The following is a description of a gene set: species: Homo sapiens Human Gene Set: GSE19941_UNSTIM_VS_LPS_AND_IL10_STIM_IL10_KO_MACROPHAGE_UP Bone marrow-derived macrophages were produced from mice lacking IL-10 alone (IL10-def) or mice lacking both IL-10 and the p50/p105 subunit of NF-kB (p50/IL10), and left unstimulated, stimulated with LPS (1 ng/ml) or stimulated with LPS and IL-10 (0.3 ng/ml). Genes up-regulated in IL10 knockout macrophages: unstimulated versus stimulated by IL10 and LPS. from publication Yang HT, Wang Y, Zhao X, Demissie E, Papoutsopoulou S, Mambole A, O'Garra A, Tomczak MF, Erdman SE, Fox JG, Ley SC, Horwitz BH (PMID 21217011), and this is the list of marker genes: SGCE, JUNB, IDO2, FOSL2, TBC1D12, SPATS2, KLF6, FGF3, ANAPC16, GIPR, LY9, SMAP2, PDGFRB, CNTN3, SATB1, TOR1A, JUN, MYO10, ABO, TRIM54, BICDL1, VAX1, PANX1, MPPED2, TSPAN4, DYRK3, KLRK1, SSH2, HOXA11-AS, TNFRSF25, NF2, NAV3, CCDC40, GPR132, ZC3H12D, UFM1, ASB4, KCNIP4 (NCBI Gene Id 80333), PLEKHF1 (NCBI Gene Id 79156), CNGA1, IL18RAP, DCN, SLCO2A1, SH3PXD2B, SIRT6, CDKL2, SNAPC1, CACNB3, SHISA2, NPR1, ALOX12 (arachidonate 12-lipoxygenase, 12S type), YPEL5, GSTA5, DNAJB4, DOK1, VWA8, PAMR1, TNFRSF1A, KRTAP3-3, CHID1, UBA1, SPIC, GLIS3, WDFY4, LETM2, GABARAPL1, COL11A2, PPFIA4, DRD1, DZANK1, SNX20, STX7, NCOA1 (NCBI Gene Id 8648), PLCG2, FAM220A, GEM, SMTNL1, MAP3K6, MOB3A, MN1, MDFIC, MPST, TAX1BP1, CYP11B2, CAVIN2, OSBPL10, ACSBG2, PCED1B (NCBI Gene Id 91523), MCTP2, ZC3HAV1, BICD2, NGF, NECAP2, SMAD3, GPR137, TMEM104, RAD52, LTB4R, B3GNT8, DNAJC16, TMPRSS5 (NCBI Gene Id 80975), SLC39A2, SLIT2, PTPN14, NAPB (NSF attachment protein beta), TLL1, ZFP90, SCAMP3, SELP, SAA1, SP110, ZSWIM9, ALDH1L1, GALNT2, CBY2, FAAP20, FRMD4B, ZNF768, SLAMF1 (signaling lymphocytic activation molecule family member 1), KCNC1, RRM2B, TBXT (NCBI Gene Id 6862), B4GALNT4, LONRF1, STMN4, SKAP2, RDH14, ZNF394, CHMP1B, ZC3H12A, ETNK1, FN3K, MYL9, UPP1 (uridine phosphorylase 1), FERMT3, GREM1, SLC18A1 (NCBI Gene Id 6570), PLAC8, FAM221B, FAM135B, IL12RB2, COL16A1, C1QC, VEPH1, ERN1, VSIR, SMURF1 (NCBI Gene Id 730332), TMEM151B, PTPRK, INHBA, RIT1, CCER1, CCDC88C, C19orf12, FRK, CYSLTR2, AMZ1, CD79A, IRF1, IL1R2, ABAT, NAPA, MYO15A, DDRGK1, GNPDA2, MEIKIN, NFAT5, MALAT1, AGPAT5, ARID5B, PTPRA, NAT9, PACS2, PTGR3, EDNRB, LRP4, MIR22HG, CIMIP5, EBF1, CHST8, KLHL6, ABCC9, PMP22, PAQR9, CD86, UXS1, ETV1, ITGB1BP1, GSDME, ERP27, ICAM1, HPN (NCBI Gene Id 3249), TLR8, TDRD1, SCOC, COX18, MPP4, FAM177A1, FGF23